The following is a description of a gene set: Mouse Gene Set: GOCC_MUSCLE_TENDON_JUNCTION A cell-substrate junction found at the terminal anchorage site of skeletal muscle cells to tendons. species: Mus musculus, and this is the list of marker genes: Itga7, Cib2, Hmcn1, Nrap (nebulin-related anchoring protein), Smpx, Neurl2